Given this list of marker genes Csl, Acly, Pck2, Mdh1, Mdh1b, Cs (citrate synthase), Got2, Pck1, Got1, Pcx, Fahd2a, Nit2, Fahd1, here is a description of the gene set: Mouse Gene Set: GOBP_OXALOACETATE_METABOLIC_PROCESS The chemical reactions and pathways involving oxaloacetate, the anion of oxobutanedioic acid, an important intermediate in metabolism, especially as a component of the TCA cycle. studied in species Mus musculus